The following is a description of a gene set: species: Homo sapiens Human Gene Set: KEGG_MEDICUS_REFERENCE_LPAR_GNB_G_RHO_SIGNALING_PATHWAY Pathway Definition from KEGG: LPA -> LPAR -> GNB/G -> RHOA LPAR-GNB/G-Rho signaling pathway. Pathway ID: N00408. Pathway type: Reference. Pathway class: nt06167 Human cytomegalovirus (HCMV)., and this is the list of marker genes: GNG3, GNG13, LPAR3, GNB4, GNB3, GNG8, GNG2, GNG5, GNG10, GNGT2, LPAR2, LPAR5, GNGT1, GNB1, GNG11, GNB5, GNG7 (G protein subunit gamma 7), LPAR4, LPAR1, GNB2, GNG12, GNG4, RHOA